The following is a description of a gene set: from publication Cui A, Huang T, Li S, Ma A, Pérez JL, Sander C, Keskin DB, Wu CJ, Fraenkel E, Hacohen N (PMID 38057668) Cytokines mediate cell-cell communication in the immune system and represent important therapeutic targets. A myriad of studies have highlighted their central role in immune function, yet we lack a global view of the cellular responses of each immune cell type to each cytokine. To address this gap, the authors created the Immune Dictionary, a compendium of single-cell transcriptomic profiles of more than 17 immune cell types in response to each of 86 cytokines (>1,400 cytokine-cell type combinations) in mouse lymph nodes in vivo. A cytokine-centric view of the dictionary revealed that most cytokines induce highly cell-type-specific responses. For example, the inflammatory cytokine interleukin-1β induces distinct gene programmes in almost every cell type. A cell-type-centric view of the dictionary identified more than 66 cytokine-driven cellular polarization states across immune cell types, including previously uncharacterized states such as an interleukin-18-induced polyfunctional natural killer cell state. Genes positively differentially expressed in cell type: Langerhans upon treatment with cytokine: IFN-γ in mouse lymph nodes in vivo. Mouse Gene Set: CUI_LANGERHANS_IFNG_RESPONSE_UP species: Mus musculus, and this is the list of marker genes: Apool, Txndc17 (NCBI Gene Id 68102), Gbp8, Parp12, Wars1, Casp4, Cxcl10, Rnf114, Ocln, Irf1, Stat1, Elmo1, Sppl3, Parp9, Fbxw17, Cd274, 9930111J21Rik2, Nck2, Cxcl9, Klf13, Bcl2l11, Slc30a4, Irf9, Pkib, Ifi47 (NCBI Gene Id 15953), Ubd, Gbp4, Glipr2, Brd2, Chic2, Pml, Nlrc5, Insl6, Psmb9, Cpne3, Gpr141, Irgm2, H2-T23, Efhd2, Stat3, Rbl1, Plaat3, Gbp2, Tmsb10, Bst2, Ctsc, Sp110, Gyg1, App, Dtx3l, Akap9, Psmb10, Lima1, Psmb8, Snx10, Calhm6, Gbp3, Foxk1, Rxylt1, H2-D1, Apobec3, Samhd1 (SAM domain and HD domain, 1), Slfn5, Tmbim6, Irgm1, Mbd2, Jpt1, B2m, Gbp5, Igtp, Card19, Rassf3, Arhgap30, Rnf19b, Aftph, Mpeg1, Ankrd12, Irf8, Anxa4, Ifi204, Lamp2, Tap1, Vim, Tgtp1, Wsb1, Casp1, Leprotl1, Parp14, Psme2, Ube2l6, Serpina3g, Rabgap1l, Bax, Zbp1